Given this list of marker genes TTC7B, SHANK3, NDUFA4L2, AICDA, ITIH5, FAM107A, CAV1 (NCBI Gene Id 857), LIFR, ZEB2, MSRB3, SLC7A2, MYCT1, RAI14, PLAT, WWTR1, RBM15-AS1, SNAP91, IGFBP3, SOX18, PLEKHA4, NSG1 (NCBI Gene Id 27065), GIMAP8, ANXA6, GDNF, ETV1, ADAM33, PTPRM, KLHL5, MMP2, OLFML2A, PAPPA, GIMAP7, ZKSCAN8P1, ENG, STEAP4, BMPER, EMILIN1, FBXL7, AMOTL1, CLDN5, RBPMS, WNT5A, TSHZ3, MAF, LTBP2, ALKAL2, LRRC49, COL12A1, ASAP1, HS6ST1, C1R, INHBB, FENDRR, FGD5, MRC2, MCAM, ADAMDEC1, RECK, CYGB, PPP1R16B, AEBP1, NID1, CTSF, CPAMD8, PTCH1, EVA1B, NES, LOX, A4GALT, IGDCC4, EGFLAM, MSN, SLC2A3, ELMO1, ADAM28 (NCBI Gene Id 27337), CSF3R, COL6A3, IGFBP6, TMEM204, OR7E47P, RAMP3, CLIC2, JAM2, COX7A1, PLAU, CLEC14A, FKBP10 (NCBI Gene Id 60681), MAP7D3, GNG11, MEIS2, ITGA11 (integrin subunit alpha 11), LAMC3, FLNA, HIGD1B, HEG1, SYDE1, LGI4, TNS1, KANK3, LY6E, C2orf74-AS1, HECW2, THBD, EHD2, NFATC4, THSD1, ENHO, A2M, C14orf132, MAP1B, EMCN, NOTCH4, COL6A2, FILIP1L, KIFC3, TPM2, MXRA7, LIMS2, KCNJ8, NR2F1-AS1, PCOLCE, PGF, BCL6B, TMTC1, EFEMP1, AXL, RBP1, CBX6 (chromobox 6), CDH13, RGS5, GJA1, PCDH19, CLEC11A, CNTLN, FABP4, CD93, TCF21, SNED1, NUAK1, RAB34, SMARCA1, ADGRL3 (NCBI Gene Id 23284), COL18A1, TNFAIP2, CYP27C1, RAPGEF3, MMP19, ADAM19 (NCBI Gene Id 8728), TRPA1, TEK, SNAI2, GLIS2, LIMCH1, WWC3, LAMB2, TGFBR3, SLC15A3, ISLR, COL5A2, DLC1, VCAN, IGFBP7, ADH1B, CXCL12, CD36, CFH, FERMT2, OLFM1, GPX3 (glutathione peroxidase 3), ITGA7, SHC2, ANKRD20A8P, RYR3, PTH1R, NEGR1, PDLIM7, SLFN11, SDC2, COL13A1, PDE1C, COL14A1 (collagen type XIV alpha 1 chain), ARL10, LINC01876, ENPP2 (NCBI Gene Id 5168), TCF4, OBSCN, LAMA4, IFIT5, WFS1, ADAMTS1, BMP4, MFGE8, ADAMTS5, POU5F1P4, CAVIN1, ABLIM3 (actin binding LIM protein family member 3), COL4A1, ETS1, APLNR, AOC3, MAPK10, LCA5L, SERPING1, COLEC12, SGTB, TSPAN4, PDGFRB, CAVIN2, PTCH2, SAMD4A, PHF10, RAMP2, TET1, PHGDH, COL4A6, EFEMP2, PDPN, CCL11 (NCBI Gene Id 6356), ACKR3, ACSL4, APOD, SGIP1, ARHGAP29, CNRIP1, SLC24A3, COL3A1, TRIM49B, RASIP1, SOX7, AGT, GJA4, ITPR1, CCDC8, PEAR1, FOXQ1, MXRA8, COL4A5, MMP11, CAV2, FADS1, KANK2, ZNF155, APOL4, QKI, FST, ARMCX1, PLEK, TRPC1, PLAC9, TMEM273, IL33, VSTM2A, GIMAP6, ADGRB3, PDE1A, MYL9, FAM24B, HOXB2, CHST7, CHL1, TIMP2, LMOD1, SPARCL1, LAMA5 (laminin subunit alpha 5), CYBRD1, DNM3OS, SPON2, ZNF521, APOE, ZCCHC24, F10, FBLN5, MAGI2-AS3 (NCBI Gene Id 100505895), ZEB1, CHST11, CXCL14, SCD5, ENSG00000275563, FBN1, CSPG4, TSPAN9, CLEC3B, RFTN1, TIMP3, IRAG1, SOX6 (SRY-box transcription factor 6), MX2, WWC2, PINLYP, CD4, CCM2L, BST2, PITX1, GULP1, ANGPTL2, ANXA1, STC1, EDNRA, SEPTIN4, LINC01082, FAM20C, CYYR1, EMID1, SDC3, FAM13C, MXRA5, EGFL7, ARHGAP6, TRPV2, ACTA2, COL27A1 (collagen type XXVII alpha 1 chain), ABCA8, PGBD1, JAM3, COL1A1, CCDC80, SCARA5, TSHZ2, CRISPLD2, NDUFAF4P1, RBMS3 (NCBI Gene Id 27303), PTPRS, STOM, PDGFRA, ITGA1, STARD8, CDH6, RBMS1 (NCBI Gene Id 5937), SGCE, TSPAN11, NKX2-3, COL4A2, GKN1, ECSCR, HTR3B, TMEM119, SYNPO2, ADGRF5, LRRN3, VSTM2A-OT1, ANGPT1, C8G, ECM1, PPP1R18, FRMD6, ISYNA1, CCDC102B (coiled-coil domain containing 102B), ABI3BP, CDH5, COL6A1, SCARF2, CDH11, FXYD1, RFLNB, PKD2, CAVIN3, CEP112, LUM, LBH, HTRA1, IGFBP5, DKK3, LRRC32, PCAT19, BGN, GLI3, GLP2R (glucagon like peptide 2 receptor), NNMT, CRIP2, RASAL2-AS1, PTN, SERPINF1, PECAM1, LAMC1, SCUBE2, SNX18, DACT1, OLFML3, TUBB6, TNS2, GUCY1A1, PDGFD, THY1, SGCD, PTGS1, RPS6KA2, C1S (complement C1s), MGP, LDB2, VWF, PLXND1, FOXF1, GRK5, CPED1, F2RL3, SLC12A4, MEIS3, SPARC, CSMD3, SLC38A6, XIRP2, FBLN1, MCTP1, DZIP1, KIRREL1, COL1A2, ADGRA2, ANKRD29, PDE7B, PMP22, CALD1, ANTXR1, NEXN, PDGFC, KIAA1755, RUNDC3B, NDST1, COL15A1, PXDN (peroxidasin), LHFPL6, LRP1, NPR3, RBP5, CCL2, DPYSL3, SYNM, DCHS1, MSC-AS1, TMEM47, MAMDC2, PPP1R14A, GPC6, DYNC2H1 (dynein cytoplasmic 2 heavy chain 1), ARHGEF17 (Rho guanine nucleotide exchange factor 17), PAM, NPAS3, GBP4, ROBO4, RHOJ, UNC5C, LINC00472, SYDE2, ITGA5, NOTCH3, CD34, TBX2, GASK1B, COL5A3, IFI44L (NCBI Gene Id 10964), TGM2, MFAP4, CSF1, IL1R1, FOXF2, PLVAP, FSTL1, CLMP, RIPOR1, WDR35, GALNT15, PROCR (NCBI Gene Id 10544), SULF1, C11orf96, CALCRL, POSTN, A2M-AS1, COL5A1, SOBP, GGT5, TSPAN2, PFN1P2, STOX2, NRP1, JCAD, PDE2A, TGFBI, PREX2, ARHGEF15, JAK2, DCN, SALL1, EPIST, LCAT, RAB8B, ALDH1A3, PDLIM4, SPART, MEG3, STMN2, MMRN2, ESAM, SCN7A, S1PR3, FRY, TFPI, DMD, EDNRB, PCDH18, FGFR1, SFRP1, ZNF687, FXYD6, ZNF667-AS1, FLT1, FHL1, here is a description of the gene set: Human Gene Set: GAO_LARGE_INTESTINE_ADULT_CJ_IMMUNE_CELLS from publication Gao S, Yan L, Wang R, Li J, Yong J, Zhou X, Wei Y, Wu X, Wang X, Fan X, Yan J, Zhi X, Gao Y, Guo H, Jin X, Wang W, Mao Y, Wang F, Wen L, Fu W, Ge H, Qiao J, Tang F (PMID 29802404) studied in species Homo sapiens